Given this list of marker genes Fancb, Nipbl, Blm, Rad21l, Xrcc1, Recql5, Rad21, Rad51, here is a description of the gene set: The repair of a replication-born double-strand DNA break in which the DNA molecule is repaired using the homologous sequence of the sister chromatid which serves as a template to repair the breaks. Mouse Gene Set: GOBP_REPLICATION_BORN_DOUBLE_STRAND_BREAK_REPAIR_VIA_SISTER_CHROMATID_EXCHANGE studied in species Mus musculus